Given this list of marker genes Bcl2a1a, Mfhas1, Cd48 (CD48 antigen), Mob3a, Serpina3g, Il10ra, Serp1, Stxbp1, Cep126, Klf6 (NCBI Gene Id 97911), Stk24, Lima1, Vim, Ldlr, Gnas, Ahnak, Gnai2, Fkbp1a, Wdr83os (NCBI Gene Id 414077), Suv39h2, St8sia4, Urm1, Irf5, Ly75, Gpx1 (glutathione peroxidase 1), Tpm3, Cdkn1a, Mdm2, Olfm1, Acsl5, Sft2d2, Psen2, Ptpn1, Coro2a, Rel, 9930111J21Rik2 (RIKEN cDNA 9930111J21 gene 2), Large1, Samhd1, Anxa5, Mrpl2, Cyfip1, Cd274, Socs1, Ikzf4, Prdm1, Nrp2 (neuropilin 2), Sertad1, Gbp5, Taldo1, Diaph1, Pim1, Nr4a3, Jak2, Sh2d4a, Ifi47, Mir155hg, Jaml, Hnrnpab, Plgrkt, Rab14 (NCBI Gene Id 99047), Ikzf1, Cd302 (NCBI Gene Id 98862), Bcl2a1b (B cell leukemia/lymphoma 2 related protein A1b), Csf2rb, Kdm6a, Cst3, Psmc4, Foxn2, Traf5, Mcl1, Gpr141, Cfl1, Eif4a1, Glipr2, Cish, Cmpk1, Ccl22, Necap2, Malt1, Tprg1l, Cyrib, Csnk1d, Ccl17, Mylk, Orai1, Chd7, Myadm, Snd1, Wars1, Mier3, Dapl1, Rac3, Rap2a, Gbp2, Gpbp1, Prkcd, Pkib, Zfand6, Jpt1, Plek2, Bcl7c, Bcl2l11 (NCBI Gene Id 76339), H1f10, Nckap1l, Nup88, Bcl2a1d, Pdlim5, Camkk2, Tax1bp3 (NCBI Gene Id 76281), Eif3a, Gm266, Socs2, Tcaf2, here is a description of the gene set: from publication Cui A, Huang T, Li S, Ma A, Pérez JL, Sander C, Keskin DB, Wu CJ, Fraenkel E, Hacohen N (PMID 38057668) Mouse Gene Set: CUI_LANGERHANS_TSLP_RESPONSE_UP species: Mus musculus Cytokines mediate cell-cell communication in the immune system and represent important therapeutic targets. A myriad of studies have highlighted their central role in immune function, yet we lack a global view of the cellular responses of each immune cell type to each cytokine. To address this gap, the authors created the Immune Dictionary, a compendium of single-cell transcriptomic profiles of more than 17 immune cell types in response to each of 86 cytokines (>1,400 cytokine-cell type combinations) in mouse lymph nodes in vivo. A cytokine-centric view of the dictionary revealed that most cytokines induce highly cell-type-specific responses. For example, the inflammatory cytokine interleukin-1β induces distinct gene programmes in almost every cell type. A cell-type-centric view of the dictionary identified more than 66 cytokine-driven cellular polarization states across immune cell types, including previously uncharacterized states such as an interleukin-18-induced polyfunctional natural killer cell state. Genes positively differentially expressed in cell type: Langerhans upon treatment with cytokine: TSLP in mouse lymph nodes in vivo.